Given this list of marker genes Ncf1, Pgam1, Ifng, Cnp, Pgk2, Prkaca, Vnn1, Pgk1, Hprt1, Tpi1, Nt5c, Urah, Rptor, Pfkl, Plb1, Nudt13, Pla2g2c, Slc4a1, Entpd7 (NCBI Gene Id 93685), Pde5a, Vcp, Pfkfb2, Gck, Parp14, Entpd5, Ogdh, Pkm, Mlxipl, Fhit, Synj2, Pla2g4f, Aox1, Hif1a, Ppara, Pla2g4c, Pla2g4d, Napepld, Eno1b, Mlycd, Git1, Aldoc, Apoa2, Pfkm, Abhd6, Tigar, Plcb3, Apoc2, Abhd12, Xdh, Nudt19, Jmjd8, App, Entpd8, Pde4c, Aldoa, Pla2g4a, Nudt17, Aldob, Dnph1, Upp2, Nudt16, Pde8b, Mtch2, Fitm2, Pfkp, Etnppl, Ncor1, Nnmt, Pde7a, Pla2g1b, Sirt6, Inpp5f, Eno1, Pde7b, Entpd4b, Pnpla8 (patatin-like phospholipase domain containing 8), Ppargc1a, Dpys, Stat3, Prkag2, Ncf2, Gapdh, Prdx6b, Pla2g15, Pnpla7, Gapdhrt, Mlx, Gdpd3, Lipc, Pla2g10, Slc4a4, Hkdc1, Smpd4, Smpdl3b, Ntsr1, Sarm1, Plcg1, Pla2g4b, Pon1, Fkrp, Gmpr2, Ada, Ldlr, Art2a, Khk, Acot7 (NCBI Gene Id 70025), Aldoart1, Ppp2ca, Pde8a, Plbd2, Psen1, Cda, Igf1, Nudt18, Prdx6, Prkcd, Prxl2c, Abhd16b, Arnt, Hint1, Smpd3, Upp1, Upb1, Col6a1, Trim63, Ier3, Pgm1 (NCBI Gene Id 99957), Hk2, Apoc1, Insr, Scarb1, Zbtb7a, Myog, Abhd16a, Ucp2, Cant1, Gapdhs, Hk3, Urad (NCBI Gene Id 631440), Esrrb, Kat2b, Nudt8, Plcb1, Pnliprp2, Nudt11, Tymp, Hk1, Abcd1, Apoc2l, Bcl2l13, Nt5m, Lipa, Actn3, Mtor, Gdpd1, Sik2 (NCBI Gene Id 235344), Pde4d (NCBI Gene Id 320753), Pla2g4e, Ins2, Ep300, Slc29a1 (solute carrier family 29 (nucleoside transporters), member 1), Gpcpd1, Ins1, Arl2, Enpp7 (NCBI Gene Id 404708), Angptl3, Pla2g7, Pank4, Pklr, Pfkfb3, Gapdhrt2, Pla2g5, Eno4, Src, Prkaa1, Gda, Fbp1, Cbfa2t3, Smpdl3a, Pde4a, Plbd1, Uchl1, Galt, Mpi, Nt5c1a, Enpp3, Acot2, Nt5e, Pde2a, Smpd5, Nt5c3, Prkag1, Nudt12, Foxk2, Nt5c2, Mlst8, Tkfc, Nt5c1b, Nudt4, Dhtkd1, Gpd1, Entpd2, Mfsd8, Gpd1l, Pld2, Pnp, Smpd1, Eno3, Pde10a, Foxk1, Idh1, P2rx7, Nudt9, Dut, Eno2, Pla2g6, Nudt5, Flcn, Aldoart2, Mgat1, Uox, Galm, Gale, Nupr1, Galk1, Nudt15, Prkag3, Entpd1, Dpyd, Pgam2, Enpp5, Smpd2, Plcg2, Pten, Eif6, Nudt7, Il3, Alpi, Nudt3, Acat1 (NCBI Gene Id 235373), Abhd12b, Plpp6, Dctpp1, Zbtb20 (zinc finger and BTB domain containing 20), Pdxp, Pfkfb1, Ogt, Samhd1, Htr2a, Prkaa2, Enpp1, Slc2a6, Pde9a, Pld1, Entpd3, Hdac4, Art2b, Trex1, Nudt10, Itpa, Ddit4, Entpd4, Gpi1, Pde1a, Enpp2, Dera, Myc, Ampd3, Adpgk, Bpgm, here is a description of the gene set: studied in species Mus musculus The chemical reactions and pathways resulting in the breakdown of organophosphates, any phosphate-containing organic compound. Mouse Gene Set: GOBP_ORGANOPHOSPHATE_CATABOLIC_PROCESS